The following is a description of a gene set: The process of introducing a phosphate group to a tyrosine residue of a STAT (Signal Transducer and Activator of Transcription) protein. studied in species Mus musculus Mouse Gene Set: GOBP_TYROSINE_PHOSPHORYLATION_OF_STAT_PROTEIN, and this is the list of marker genes: Irf1, Tnfrsf1a, Il23a, Cnot7, Ggnbp2, Il3, Il18, Il31ra, Pecam1, Igf1, Fyn, Il22, Il2, Kit, Snhg20, Csf1r, Hes5, Ctf1, Il21, Socs3, Traf3ip1, Il12b, Hsf1, Hnf4a, Ptk6, Il15, Lif, Csf2, Il6ra, Crlf1, Jak1, Parp9 (NCBI Gene Id 80285), Nf2, Ifng, Tnfrsf18, Tnfsf18, Ptger4, Clcf1, Hdac2, Epo, Inpp5f, Lck, Pibf1, Il4, Il24, Arl2bp, Tnf, Lep, Cav1, Isl1, Fer, Erbb4, Il6st, Parp14, Il12a, Cd40, Ptpn2, Osm, Fgfr3, Cntf, Suz12, Ccl5, Il22ra2, Socs1, Osbp, Hes1, Il13, Hpx, Jak2, Il6